Given this list of marker genes Naa35, Lztfl1, Large2, Raf1, Reep6, Myh14, Acox1, Sp4, Aftph, Tet3, Pim3, Cptp, Lysmd1, Rpl22, Klf13, Gm5475 (NCBI Gene Id 432982), Rps29, Gsk3a (NCBI Gene Id 76828), Gm15327, Dicer1, Zranb3, Ap1m1, AI661453, Adrm1, Hdac4, Brms1, Sod1, Tpd52l2, Tmem147, Specc1, Gm16537, Med6, Arfip1, Cox5a, Ccl25 (C-C motif chemokine ligand 25), Snord118, Sac3d1, Plpp1, H4c1 (NCBI Gene Id 326619), Atf6, Actg1, Rogdi, Oser1, Mtrfr, Cdc25c, Sike1, Wbp4, Mapkapk5, Hspa9, Tmem167b, Ralbp1, Slc22a5, Kansl1, Eif4a3, Mcm4, Gm10044, Mllt11, Magoh, Gm11936, Atg16l1, Rnf44, Sys1, Ruvbl2, Lipe, Snx1, Dcaf11, Ttll5, Lasp1, Cdc42, Bad (NCBI Gene Id 12015), Ptpn6, Asap1, Elf2, Mgat2, Chmp7, Map3k4, H2bc21, Socs2, Vta1, H2ac20, Zmynd8, Flad1, Ddb1, 1600020E01Rik, Srrt, Tnrc18, Lrsam1, Cep120, Kansl2, Senp8, Ptp4a2, Oard1, Hnf4g (hepatocyte nuclear factor 4, gamma), Ubp1, Eef2, Kmt5a, Esf1, Gda, Arhgef12, Ppm1b, Rhbdd3, Xrra1, Cenpu, Vcpip1, P2ry1, Tomm20, Wee1, Cks1b, Nat10, Mtpap, Gm16083, Mllt10, Gart, Morc3, Capn10, Srpra, Deptor, Mcm7, Emg1 (NCBI Gene Id 14791), Aamp, Tmem87a, Armc1 (NCBI Gene Id 99874), Fxr2, Foxred1, H2-Q2, Mmab, Prdm10, Bok, Kdm1a, Ino80b, Sypl1, Slx4ip, Nfatc2ip, Junb, Ncapd2, Naa15, Fntb (NCBI Gene Id 70263), Dmbt1, Ppp1r16a, Rnf145, Herc1, Midn, Nlrp6, Fbxl20, Foxa3, Ppp2r5d, Stmn1, Pole3, Gm13648, B130034C11Rik, 2900093K20Rik, Krt8 (keratin 8), Sec63, Pet117 (PET117 homolog), 1700028E10Rik, Klf6, Myo1a, Macir, Zfp36, Sec23b, Arl4a, Vps72, Dxo, Ikzf5, Ndufaf4, Ewsr1, Camta2, Baz2b, Il17rb, Zfp939, Cep85, Uvrag (NCBI Gene Id 78610), Vdac3, Nectin3, Arfgap2, Naa40, Neo1, Slc2a9, Cdk5rap3, Ttll10, Cd2ap, Gm22589, Prkdc, Ndufaf8, Ddx10, Zbtb1, Vwa8, Ska2, Pcnt, Cdk2ap1, Hmgb1, Fastk, Sdf2l1, Hdhd3, Plekha3, Hnrnph1, Hmgn2, Rbm4, Nr1h2, Pdhx (pyruvate dehydrogenase complex, component X), Misp, Scnm1, Pcif1, Gpa33, Zfp46, Mbd2, Taf13, H1f4, Plin3, Sertad3, Slc39a3 (NCBI Gene Id 208667), Atp1b1, Trmt6 (tRNA methyltransferase 6), Cited2, Cyp2d26, Kifc5b, Ahr, Anapc10 (NCBI Gene Id 68999), Ivns1abp, Zfp846, Mcoln1, Tbrg4, Slc12a7, Stx5a, Cct3, Gm6658, Fastkd2, Rab10os, Arhgap19, Cic, Ccdc47, Zfpl1, Susd6, Zcchc14, 2610037D02Rik, Chdh, Smg6, Pcmtd1, Rps23, Mapkapk3, Tcp1, Cct6a, Ift52, Aph1b, Rpl3, Xrcc3, Pxdc1, Mir8120, Ssbp1, Cnot2, Anapc11, Rpl10a, Mlycd (malonyl-CoA decarboxylase), Csnk1g3, Ibtk, Psmd3, Cryzl1, Klhl25, Ip6k2, Dnajb1, Proc, Rps3a1, Mmp24os1, Usf3, Ing3, Crebl2, Harbi1, Uhrf2, Rpl18 (NCBI Gene Id 19899), H2-Q4, Tfg, Syvn1, Ccdc50, Clec2d, Cidec, Gm16675, Cog7, Tubb4b, Spint2, Abhd2, Kbtbd8, Mdc1, Dnai4, Snord59a, Hexim1, Mgat4c (MGAT4 family, member C), Pcgf3, Cds2, Pnkd, Gm26725 (predicted gene, 26725), Rnf103, Stag1, Adgrg7, H3f3b, Naa25, Nt5c, 2610005L07Rik, Ncdn, Tmem30b, Pip5k1b, Sc5d, C130036L24Rik, Ly6g2, Mir5133, Hnrnph3, Mpi, Gm15417, Cdc23, Mbtps1, Traf7 (NCBI Gene Id 224619), Hspa5, Setd1a, Gm23130, Ak2, Vapa, Rnpc3, Dda1 (NCBI Gene Id 97493), Cenpk, Zfp207, Wsb2, Srr, Zbtb25, Kctd9, Mdh1b, Eif4a1, Zdhhc5, Got1 (glutamic-oxaloacetic transaminase 1, soluble), Alg9, H2ac11, Hibch, Cdc25a, Gys1, 9430015G10Rik, Calm3, Gspt1, Msl2, Gm40332, Gpbp1, G3bp2, Dync1i2, Taf6l, 1700122E12Rik (RIKEN cDNA 1700122E12 gene), Mrps14, Arhgef16 (Rho guanine nucleotide exchange factor 16), Flywch1, Tom1l1, Tspyl1, Gm13066, Ercc6l2, Asl, Wasf2 (WASP family, member 2), Polr1f, Fech, Gm12915, Malrd1, Gm26397, Clca4b, Liph, Zswim3, Creb3, Get4, Grb2, Fgf9, Bzw1, Ppp6r3, Ech1 (enoyl coenzyme A hydratase 1, peroxisomal), Zfyve21, Mettl23, Atp5mg, Stip1, Lamp1, Dars2, Tedc1, Nherf1, Tmco4, Ten1, Kifc1, Setd3, Jakmip1, Mical2, Acot8 (acyl-CoA thioesterase 8), Tln1, Trmt1l, Rab26os, Wnk1, Klhl18, Ehd4, Ergic2, Rab2a, Mblac2, Tsfm, Ppm1k, Bod1l, Herpud1, Tdp1, 4930449I04Rik, Lgals12, Gm11423, Nampt, Top2a, D330041H03Rik, Spata1, Helb, Jmjd6, Gls, Gatad2a, Nmi, Gtf3a, Pex7, Ufm1, Gm16001, Tfcp2l1, Uqcrb, Dcaf15, Gm25280 (predicted gene, 25280), Atf7, Slc25a25, Atp5mc3, Sec31a, Smg5, Glrx5, Card10, Oxsr1, H4c8, Slc35b3, Gcnt4, Phrf1, Cetn3, Cdkn2d, Cdc42se1, Nedd1, Dhx8 (NCBI Gene Id 217207), Akr1b7, Scaf4, Det1, Irf2, Atp5f1b, Plagl2, Rb1cc1, Has2os, Akap11, 5730420D15Rik, Pygo2, Gm23664, Cda, Mre11a, Cox11, Map3k7, Vdac1, Zfp62, Efcab11, Dlgap4, Snord32a, Uspl1, Gm9929, Nosip, Fis1, Ppp3r1, Ccng2, Pip4p1, Poc5, Yif1a, Eps8l2, Tmem79, Pofut1, Cdca2, Acvr2b, Tfrc, Mphosph8, Lig3, Sec23ip (Sec23 interacting protein), Hcn1, Tmem218, Denr, Swsap1, Pcsk4, Gid8, Nhp2, Jund, Bcl3, Wbp1, Ppcs, 4930483J18Rik, Dapk3, Lcorl, Abce1, Rab5b, Sanbr, Thrap3, Slc35f5, Cyp3a25, Stt3b, Cct7, Zzz3, Rassf6, Ppp5c, Trp53, Nup133, Tnfaip3, Rabl3, Shc1 (src homology 2 domain-containing transforming protein C1), Nudt2, Fbxl19, Atf4, Jmjd8, Atp8b1, Thap1, Ubox5, Gpx4, Sfswap, Cfb (NCBI Gene Id 14962), Ttc33, Psmd5, Phf23, Saysd1, Cand1, Srrm2, Mfsd11, Dalrd3, Zdhhc16, Ngdn, Shroom3, Pnpo, Mitd1, Arih1, Serf2, Smdt1, Akt2, Capn8, Cox14, Pabir1, Mier1, Lars1, C87436, Mkks, Puf60, Slc11a2, Rras, Zbtb18, Npc1, Exd1 (NCBI Gene Id 241624), Traf2, Ggnbp2, Pnrc1 (proline-rich nuclear receptor coactivator 1), Tpp2, Gm10778, Xndc1, Rfx1, Hrob, Sympk, Ciz1, Acbd4, Brat1, Entpd7 (ectonucleoside triphosphate diphosphohydrolase 7), Dennd4b, Arhgap11a, Arap1, Vasp, Aldh4a1, Mff, Slc18b1 (solute carrier family 18, subfamily B, member 1, NCBI Gene Id 76306), Ap1g1, 1110020A21Rik, 1700040D17Rik, Hycc2 (NCBI Gene Id 52084), Stx16, Ift46, 4933405D12Rik, 6720482G16Rik, Akap1, Eif2ak2, Imp4, Ormdl3, Neat1 (NCBI Gene Id 66961), 8430429K09Rik (NCBI Gene Id 71523), Coq8a, Gm28047, Gm15908, Ccnk, Sod2, Ubb, Bltp1, Sfxn5, Hras, Stil, Odad3, Fkbp14, Bcl2l14, Slc35f2, Naprt, Nat9, Nfya, Ciao3, Phospho1, 4933406P04Rik, Cdkn3, Vps26c, Mapk14, Copz1, Dhrs9, Stk11, Rpl36al (ribosomal protein L36A-like), Sec62, Rxrb, Mmaa, Jpt2, Tjp2, Dcaf13, Cdk12, Rps15a, Nutf2, Dis3, Fbp2 (fructose bisphosphatase 2), Ckap5, 4732491K20Rik, Mtfr1, Hs6st1, Septin7, 1700056E22Rik, 4930405A21Rik, Tdrkh, Tmc6, Mttp, Hnrnpll, Sacm1l, Ap4m1 (adaptor-related protein complex AP-4, mu 1), Slc25a32, Ogfod2, Snhg8, Cstf1, Nmbr, Zranb2, Fmn1, Shoc2, 3110082I17Rik, Ift80, Gm16136, Exoc5, Rbm26, Sidt1, Elp6, Mark2, Micos10, Rfk, Slc17a4, Polr2e, Lrp1, Leap2, 4933433G15Rik, Snord1c, Mrpl51, Calr, Aggf1, Narf, Cct8, Mrtfa, Igsf9, Zbtb17, Snord60, Gm11335, 6430550D23Rik, Sesn3, Rec8, Coro1c (coronin, actin binding protein 1C), Dnajb4, Pno1 (NCBI Gene Id 66249), 1700031P21Rik, Tuft1, Dbp, Actmap, Ptgr2, Stk19, Aldob, Prdx1, 4732440D04Rik, Rnf126, Mvk, Ogdh, Noc4l, Aacs, Tmem104, Cenpl, Tomm70a, Vgll4, Psph, Tmem147os, Hnrnpr, Crocc, Glce, Nsun3, Ap5m1, Ndufa4, Myl6b, Exosc1, Mrpl11, Esrra, Ankrd16, Slc39a7, Cnnm2, Mfn2, Ugdh, Smc4, Aars1, Gabpa, Rbm14, 4933430I17Rik, Irf2bp2, Arsa, Slc43a2, Creb3l2, Prrx1 (paired related homeobox 1), H2ac14-ps, Cnot3, Trib1, Prkcz, Ireb2, Mm2pr, Ccnb1, Snora3, Rnf185, Rnf24, Mef2d, Mdn1, Agps, Gucy2c, Dnal4, Chmp5, Gm43391, Fkbp8, Dennd2d (DENN domain containing 2D), Gm25744, Dolpp1, Exosc2, B230354K17Rik, Vapb, Mkln1os, Atp5mj, Cenpt, Dtl, Qrsl1, Kxd1, Alyref, Erg28, Cd55, Derl1, Fgfr1op2, Pja2, Khdrbs1, Crcp, Epas1, Smim6, Sptlc2, Ptbp1, Gm2093, 1110038B12Rik, Crebrf (NCBI Gene Id 77128), Gngt2, Alg12, Poli, Eif4g2 (NCBI Gene Id 77989), Maf, Dag1, Gm15927, Tmem25, Gm9515, Mrpl35, Zmynd19 (zinc finger, MYND domain containing 19), Ppp1r1b (protein phosphatase 1, regulatory inhibitor subunit 1B), Ss18l2, Nfe2l1, Rps26, Zmynd12, Anapc5, Wdr12 (WD repeat domain 12), Lrrc56, Prkce, Snx3, 1810037I17Rik, Habp4, Abi3, Pip5k1a, Mmut, Atg4c, Ppp4r3b, Ppm1g, Fbxl3, Ndfip2, Ndufb3, Dyrk1b, Dctn4, Ccdc115, Zng1, Gm12279, 1700041G16Rik, 4933406C10Rik, Dhx32, Rimoc1 (NCBI Gene Id 223279), Mrpl1, Snx14, Ctcf, Akr1c12, Recql5, Syne2, Polr3k, Slc25a42, Lclat1 (lysocardiolipin acyltransferase 1), Nop9, Kmt2a, Gm4890, Socs3, Zfp41, Eif5, Trim31, Scamp5, Cyb5b, Eif2ak3, Ubxn1, Lmnb1, Lsm8, Rrm1, Cltc, Atp5mc2, Rpl12, Gcat, Ramacl, Otud5, Trmt1, Tmem150b, Kif9, Lsg1, Herc2 (NCBI Gene Id 233281), Hmgcs1, R3hdm1, Gm15559, Soat2, Ube4a, Tmbim1, Hnrnpl, Dhrs1, Tsacc, Ddx42, Eif4b, Lsm4, Mnt, Apoc3, Slc26a3, Pkm, Slc35b1, Foxo6, Gsta1, Map3k1, D030028A08Rik, Nans, 2900052L18Rik (RIKEN cDNA 2900052L18 gene), Canx, Slc41a2, Gltp, Gnpda1, Hsd17b13, Chst4, Wdr89, Eif1, Snord3a, Pbld2, Vil1, Smim27, Iffo2, Ubc, Usp42, Zbtb20, Dck, 9130604C24Rik, Ints13, Eea1, Kifap3, Hnrnpul1, Prdm9, Hapstr1, Snord43, Styx, Pcbp1, Bpgm, Sec24a, Rnf121, Cdca5, Arl4aos, Ist1, Ube3a, Elf1, Fank1, Gm11457, Mir1945, Sp2, Myo9a, Tepsin, Tomm40l, Ccdc62, 4932412D23Rik, Rnf186, Sec16b, Slc39a4, Matr3-ps2, Ddit4, Carmil1, Adnp, Chd6 (NCBI Gene Id 74009), Pdss1, Eef1a1, 1600012H06Rik, Cap1, Chchd2, 2010110K18Rik, Dcun1d4, Rps7, A430035B10Rik, Skil, Snora24, Dgat1, Phykpl, Zmym6, Kbtbd8os, Matr3, Ndufaf5, Srsf2, Gpank1, Abhd11os, Slc25a23, Fubp1, Hnrnpa3, Cant1, Rpl13a, Dnaaf10, Rubcn, Secisbp2l, Zfp526, Pik3r1, Mir21a, Nip7, Actl6a, Pias4, Mtmr4, H2az2, Csnk1g2, Itsn1, Rpl26, Coa6, Marchf7, Rragc, Tns3, Fastkd5, Asph, Rnps1, Patj, Nol9, Sdcbp2, Nbeal2, Phb2, Ubr3, Wdr75, Ncl, Usp28, Sowahb, 4930592C13Rik, 1110059G10Rik, Gsk3b, Tada2b, Mrpl18, N4bp2l2 (NEDD4 binding protein 2-like 2), H2bc11, BC016579, Cog8, Gm21992, Cpt2 (NCBI Gene Id 12896), Otud6b, Coro2a, Mettl16, Tarbp2, Smc3, Tnfsf13b, Cdc42ep5, Osbpl7, Gapdh, Immp1l, Gm20186, Arhgef1, Ep400, Zxdc, Tm2d2, Kifbp, Hsd17b12, Vcl, Frg1, Eps8l3, Gm24204, Cox18, Mypop, Cyp51, Rad51, F630206G17Rik, Pold3, Rcan1, Ddx51, Lamtor1, Atg13, Snapc2, Cdk5, Xbp1, 1700018L02Rik, Polr3g, Numb, Ywhag, Acadsb, Klhdc10, Zbtb7b, Bnip1, Stat2 (signal transducer and activator of transcription 2), 1700034P13Rik, Tesk2, Kdm3a, Cox7a2, Isoc2b, Cdk2ap2, Lin52, Supv3l1, Prr11, Trappc9, Chmp6, Igsf5, Zfp961, Ahcyl2, Rtn4ip1, Kmt5c (NCBI Gene Id 232811), Mapk6, Tardbp, BC049715, Prrg2, Ap3m2, Rbm25, Nedd9, Glrx, AU040320, Stxbp4, Pradc1, Pafah2, Crtc2, Hdgfl2, Prkcsh, Ddx50, Suz12, Ypel5, Pdia6, Chp1 (calcineurin-like EF hand protein 1), Dcaf12, Efna1, Ganc, Rps12, Gm10138, H2aj, Clcn2, Usp43, Adtrp, Grhl2, Nabp2, Adipor2, Wbp11, Rpl37, Dst, Ints11 (integrator complex subunit 11), Ceacam18, Hnrnpa0 (NCBI Gene Id 77134), Pcm1, Tmem11, Mrps30, Gm6410, Hacd2, Cyp3a13, Selenoi, Zfp512, Ctnnd1, Slc25a39, Aurka, Fstl3, Abcf2, Gm15368, Rprd2, Rnu11, Snx7, Mob3c, Ankrd54, Mir22hg, Elp4, Glt28d2, Mafb, Pan3, Prss27, Gng5, Spcs2, Osbpl9, Tlcd2, Ephb3, Clasp1, Tmem18, Adh6a, Carf, Llgl2, H4c4, Rcor1, Rpl27a (ribosomal protein L27A), Gm26761, Cyth2, Epb41, Creld2, 5031425E22Rik, 2610528J11Rik, Gtf2e1, Foxn2, 3110045C21Rik, Kat14, Cdc123, Marchf8, Skap2, Rbm47, Rmdn3, Gclm, Arf1, Agtpbp1, Rps14, Ms4a8a, Dusp10, Kmt2c, Hdac1, Snrpa, Etfbkmt, Snhg16, Adam9, Ahctf1, Glcci1, Zfp346, Zfp696, Timm10, Yif1b, Aktip, Fbh1, Kmt2e, Rere, Phf12, Slc25a3, Ces2c, Mcm8, Yes1, Scp2, Dstn, Hnrnpf, Ppwd1, Zfp703, Svip, Gm15938, Fgd4, Mphosph9, Tmem42, Lnpep, Srsf4, Ubald2, Zbtb40, Rpl38, U2surp, Chaserr, D130043K22Rik, Muc13, Asxl1, Sphk2, Bcar3, Oga, Pex16, Nup153, Ccdc96, Hsd17b7, Aldh6a1, Sfpq, Rassf7, Slc16a3, Pprc1, Uap1l1, Cuta, Pars2, Churc1, Wrap53, Tbl1xr1, Cbr4, Eif2a, Bag1, Opa3, Nup214, Thada, Mrpl15, Tcerg1, Idi1, Cx3cl1, Atp5pf, Ccnt1, Tas1r1, Pop7, Pgk1, Xntrpc, Mob4, Sap30bp, Swt1, Gtf3c6, Psmc6, Serp1, Tmed2, Ddx39b, Pwwp2a, Fas, Ptpn4, Nudt5, Spdl1, Gm9530, Ms4a10, Mrpl30 (mitochondrial ribosomal protein L30), Son, Adam10, Slc4a2 (solute carrier family 4 (anion exchanger), member 2), Phf14, Magohb, Rictor, Hmg20b, Apip, Ankrd9, Med26, Nfkbiz, Gm12870, Ergic3, Csnk2b, Tle4, Kif24, Lims1, Gm5590, Zfp574, Get1, Dido1, Cdc5l, Zc3h12a, Rmdn1, Fnbp1l, Birc6, Wfs1, Ppp6c, Aqp8, Bclaf1, here is a description of the gene set: Mouse Gene Set: KDM4B_TARGET_GENES from publication Yevshin I, Sharipov R, Kolmykov S, Kondrakhin Y, Kolpakov F (PMID 30445619) Genes containing one or more binding sites for (Kdm4b) in their promoter regions (TSS -1000,+100 bp) as identified by GTRD version 20.06 ChIP-seq harmonization. studied in species Mus musculus